Given this list of marker genes DLG1, GDF11, MED12, ARHGEF38, PTCH1, MSX1, DLX4, SIX3, CDH1, YAP1, GLI2, CHUK, IRF6, PDGFRA, SUMO1, SLC26A2, BMP4, SPOP, CTNND1, RIC1, ARHGAP29, NECTIN1, RPL26, TP63, ASXL1, COBLL1, CDH11, KAT5, here is a description of the gene set: Human Gene Set: HP_NON_MIDLINE_CLEFT_PALATE Non-midline cleft palate studied in species Homo sapiens